The following is a description of a gene set: Gap junction assembly species: Homo sapiens Human Gene Set: REACTOME_GAP_JUNCTION_ASSEMBLY, and this is the list of marker genes: GJA3, TUBA3C, TUBB8, TUBA4A, TUBB3, TUBA8, GJB4, GJB5, TUBB4A, TUBA3E, GJA8, GJA9, GJD4, TUBA4B, TUBA1B, GJC1, GJA4, TUBA1A, TUBB6, GJB7, GJA1, TUBB4B, GJB2, GJA10, GJD3, TUBAL3, TUBB1, GJB1, TUBA1C (tubulin alpha 1c), TUBB2B, GJB3, GJB6, TUBA3D, TUBB2A (tubulin beta 2A class IIa), TUBB8B, GJD2, GJC2, GJA5